Given this list of marker genes PPP2CA, PRICKLE2, UBFD1, TAF4, ADIPOR2, PAIP2, DYNLL1, UBE2K, EN1, CTBP1, MTMR4, CCPG1, BOLA2, MAPK6, BCAS3, CILP, VPS37A (NCBI Gene Id 23687), GK5, FAM53C, TCF20, SPTY2D1, NPEPPS, SLC25A23, PLA2G4A, BCL2L2, GTF2E1, NXPH1, ZDHHC5, PDP1 (pyruvate dehydrogenase phosphatase catalytic subunit 1), MOB3B, DYRK1A, LZTS1, CELF1, RHOT1, CNOT7, PPP1R12A, ILRUN, HOXC8, OGT, ADGRL1, GTDC1, PLXNB1, KIF24, TLN1, DCLK1, CBX1, OCRL, MEIS1, SLC25A27, DHX57, RAB8B, PPM1G, CPSF7, ZFAND5, EEF2, PCDH17, AMMECR1L, ZNF644, SYNCRIP, ZFC3H1, UTP15, ITPKA, HYCC2, RBM14, FLRT3, SNX27, CDC42EP3, DPP10, SP1, TCF4, TCF12, AXIN2, SH3GLB1, CALU, PRRX1, GGA3, DOCK11, ABCC5, ZIC1, ACVR2A, EPB41L4B, RORC, LDB1, RAB35, EIF4E, FBXO11, ADGRG6, FOXO3, RSBN1, CADM1, P4HA1, GIGYF2, SLC6A9, EPHB3 (NCBI Gene Id 2049), here is a description of the gene set: studied in species Homo sapiens Human Gene Set: GAGACTG_MIR452 Genes having at least one occurence of the motif GAGACTG in their 3' untranslated region. The motif represents putative target (that is, seed match) of human mature miRNA hsa-miR-452* (v7.1 miRBase).